Given this list of marker genes PDHX, ACOT11, GLRX, ATP5MGL, GFUS, ERH, AFMID, NT5C, UNG, NDUFB7, ACOT12, GUCY2D (guanylate cyclase 2D, retinal), HAAO, TDG, DNPH1, DHTKD1, PDK2, TPST1, PPCS, ACAT1, BPNT1, PRKACA, CDADC1, TSPO, GPI, PKLR, PMM2 (phosphomannomutase 2), NDUFA2, AADAT (NCBI Gene Id 51166), GCK, GMPPB, ACO1, PRKAG2, PUDP, ACSBG1, CBR4, RRM1, ME1, SDHB, SLC4A1, MYH8 (NCBI Gene Id 4626, myosin heavy chain 8), PFAS, AK4, GARS1, ACSL3 (acyl-CoA synthetase long chain family member 3), KYNU, MYH4, NDUFB2, TMSB4X, HDAC4, TTR, CLPX, NDUFB6, GOT2, SARM1, ENO3, GUCA1A, GDA, PIPOX, INS (NCBI Gene Id 3630), KAT2B (NCBI Gene Id 8850), ADCY9, RORA, SULT2B1, TAFAZZIN, ARL2, PPT2, UGGT1, PGM3, DGUOK, MMUT (NCBI Gene Id 4594), EP300, NUDT10, FLCN, TALDO1, NT5M (5',3'-nucleotidase, mitochondrial), GMPS, NDUFB11, RRM2B, BAAT, MDH1B, ATP5MC2, ACSM2A, PDE8A, PDE1A, ADA, RNASEH2B, GNPNAT1, PAPSS1, NME5, PRPS1L1, ENPP4, NDUFS5, MYH3, HACD1, APOBEC3G, AMDHD2, AICDA, GFPT2 (glutamine-fructose-6-phosphate transaminase 2), MDH2, RD3, MPP1, NDUFA3, TK1, STOML2, ACSM3, DCTD, NTHL1, BCKDK, TK2, GPAT4, PGK1, MAPDA, ATP5MC1, ASPDH, NDUFA5, NUDT13, PTH, PDE7B, HPRT1, ATP5F1C, REXO2, GIT1, FLAD1, ADSL (adenylosuccinate lyase), AMPD2 (adenosine monophosphate deaminase 2), ACOT8, ACACB, PPT1, ACTN3, GNAI3, ATP6V1A, MT-ND1, NUDT1, TGFB1, TJP2, DHFR2, PGM1, ACSBG2, MTHFD1, SLC25A13, BAD, NNT, NUDT15, NME3, NDUFB10, ABCD1, JMJD8, DNAJC30, AK5, ACSM5, EXTL2, PDE7A, SLC2A6, PGD, ATP5MJ, SULT1C4, ACSL6, NUDT14, PPP2CA, ADSS2, OXSM, GFPT1, PRPSAP2 (phosphoribosyl pyrophosphate synthetase associated protein 2), PDE4B (NCBI Gene Id 5142), MT-ATP8, HMGCS1, ATP5MC3, ZBTB7A, SLC52A3 (NCBI Gene Id 113278), ADCY3, PDE4D, PRKAG3, TREX1, IER3, SUCLG2, TPK1, H6PD, TP53I3, SMUG1, DPYSL3, DHODH, PAICS, NUDT16, ATP5PF, UQCC3 (NCBI Gene Id 790955), NUDT9, NT5C1A, SULT1C3, MYH7, IMPDH2, EIF6, PFKFB3, NT5C3B, SHMT1, MGAT1, SRC, P2RX7, MPC2, RPTOR, G6PD, AK1, NDUFB5, TIGAR, ALDH6A1, NMRK2, CMPK2 (NCBI Gene Id 129607), AK3, NUDT4, PFKP, MT-ND6, MLST8, TREM2, DLG1, PAPSS2, LACC1, MACROH2A1, MT-ATP6, DCK, FOXK2, AMPD3, NDUFA13, NDUFA6, IL4, NADK2, BLOC1S6, SLC4A7, SLC27A2, MVD, SDHC, NANP, FCSK, ASMTL, ADCY2, URAD, RRM2, NT5C1B (NCBI Gene Id 93034), NDUFC1, PDE5A, ACMSD, OPA1, HTR2A, BPGM, PPCDC, MAP2K1, MTHFD2L, UCP2, ELOVL7, SNCA, ELOVL5, ATP1B1, ADK, ELOVL4, NDUFS4, ATP6V0C, ACSL1, MVK, UAP1, ADCY7, PFKL, NADSYN1, GAPDH, NUDT8, HSPA8, ACACA, TDO2, PARK7, NMNAT2, AMPD1, BEND3, MFN1, DDIT4, DUT, IDH1, ZBTB20, NDUFA8, MYH6, HSD17B4, ACOT1 (acyl-CoA thioesterase 1), NAMPT, HKDC1, DLG2, COX11, APP, CMPK1, UCK2, CD38 (CD38 molecule), ATP5F1EP2, EFL1, ALDOA, IGF1, PRPS2, PPARA, SUCLA2, ATIC, ACOT2, ITPA, HSPA1B, MACROD1, ENO1, NUDT5, PDK3, PANK4, GAPDHS, PRKN, LRGUK (NCBI Gene Id 136332), TPI1, NANS, PRXL2C, MDH1, OLA1, OGT, CRMP1, PGAM2, AASS, UPP1, THEM5, QNG1, ATP6V1B2, ACSL4, HK1, UXS1, GNPDA1, NOCT, ENPP1, COASY, ADSS1, FHIT, APOBEC3C, NDUFA9, GUCA1ANB-GUCA1A (NCBI Gene Id 118142757), SLC25A18, KARS1, PGLS, CMAS, ELOVL2, TBPL1, GNPDA2, TGDS, LIPA, VPS9D1, IFNG, SULT1A1, FIS1, PGK2, PDHA2, FBP1, NMRK1, PSEN1, HMGCS2, ATP5MK, NT5C3A, SUCLG1, GMDS, GNE, NDUFA11, ATP1A2, DCTPP1, GPAM, AK8, MLXIPL, NDUFV3, SELENON, ELOVL1, ATP7A, NADK, NPPC, AK6, MAPK1 (mitogen-activated protein kinase 1, NCBI Gene Id 5594), UPRT, ADCY10, PDK4, NME7, FAR2, UGDH, SHPK, PARG, ALDH1L2, NDUFB1, GLYAT, GUCY2C, HIF1A, DCAKD, UPB1, HACD2, ARNT, STAT3, GUCY1A2, UGP2 (UDP-glucose pyrophosphorylase 2), PMM1, NDUFS3, LETMD1, NDUFV1, NOX1, NDUFA10, MTAP, HK2, ELOVL3 (NCBI Gene Id 83401), NCOR1, NDUFB9, NUDT2, GALT, DPYS, XDH, DTYMK, ATP5F1D, TP53, PGAM4, DGAT2, ACLY, IDH2, ENTPD1, MT-ND5, VCP (NCBI Gene Id 94731), VNN1, CTPS1, ATP5MF, ENTPD4, MT-ND4L, GUCY1B1, TYMP, MT-ND4, ATP5F1B, ACSF2, DPYD, GCDH, UCHL1, UCK1, CMAHP, TYMS, NUDT3, NUDT19, DPM1, ACOT7, TPST2, PFKFB2, NME4, ME2, PDK1, MT-ND2, GUCY2F, GPD2, ATP5PO, NEIL1, GMPR2, LDHB, RPIA, NDUFS6, ACSL5, NDUFC2, NDUFS1, FMO2, MIR675, SULT2A1, CSGALNACT1, PRTFDC1, NPPA, INSR, UGGT2, CROT, TKT (transketolase), PDE4C (phosphodiesterase 4C), NME2, ACOT6, FAR1, NPR1, ENTPD8, CARD11, DERA, OARD1, ENSG00000293349, ADCY4, NPR2, PRPSAP1, NUPR1, DNM1L, NDUFB8, MCCC2, NDUFB3, SDHA, NAXD, PFKM (NCBI Gene Id 5215), NDUFA12, MCEE, SLC25A25, FITM2, PRPS1, KMO, IMPDH1, DGAT1, RAN, CTPS2, HMGCR, SLC25A22, CASK, FIGNL1, ADA2, FUOM, PDHA1, NDUFV2, NAPRT, ALDOC, ENO2, CTNS, ICMT, PDE4A, MLYCD, MTCH2, PGM2, PRKAA1, NAXE, DMAC2L, ADCY6, NDUFS2, PNP, OGDH, ACP3, PGAM1, IDO2 (NCBI Gene Id 169355), PTHLH, HSPA1A, ATP5IF1, DIP2A, NUDT11, TECR, LDHA, DPYSL2, SLC35A3, SLC25A11, GALK1, ATP5ME, ATP5MG, ENPP3, COL6A1, ACSM6, SLC35C1, NMNAT3, NT5C2, OGG1, GMPR, PANK2, GPD1, NDUFA7, PANK3, NUDT7, NME1, CAD, QPRT, GNMT, CACNB4, ALDH1L1 (aldehyde dehydrogenase 1 family member L1), ACOT9, NEIL2, ENTPD2, ACSF3, ATP5F1E, NMNAT1, PRKAG1, SULT1B1, PKM, OGDHL, ATP5PD, PARP1, NPPB, RPE, SULT1A3, FPGT, PINK1, GUCY1A1, ACSM1, RAB23, EPHA2, GUK1, MAGI3, ADPGK, ADCY8, ATPSCKMT, ABHD14B, NME9 (NME/NM23 family member 9), UCKL1, MACROD2, UAP1L1, FAM3A, LRRK2, ABCC6, NDUFS7, NDUFAB1, NDUFS8, AK7, SULT1E1, CDA, SMPDL3A, PC, ADCY5, NUDT12, MPI, ATP5F1A, NME6, DCXR, DLST (NCBI Gene Id 1743), ANTKMT, SULT1A2, ABCC9, NAGK, ATP6V1B1, UPP2, KDM1A, IDO1, FUT8, CNP, HTD2, PDHB, RPEL1, ATP5PB, SPHK2, MT-ND3, GIMAP7, TRIM63, CPS1, DPYSL5 (NCBI Gene Id 56896), AK2, FKRP, NDUFB4, ADCY1, NUDT4B, RBKS, CBFA2T3, ELOVL6, FOXK1, NDUFA1, ENTPD3, PANK1, NT5E, LDHC, PMVK, GTPBP1, ACSM2B, PID1, SLC25A12 (solute carrier family 25 member 12), MBD4 (NCBI Gene Id 8930), RFK, HK3, PDE10A (phosphodiesterase 10A), BCL2L13, ALDOB, ACSM4, DPYSL4, DLD, SLC4A4, HINT1, FASN, MFSD8, GSK3A (NCBI Gene Id 2931), AK9, ACOT4, PRKAA2, GPD1L, B4GALNT2, GOT1 (glutamic-oxaloacetic transaminase 1), SULT1A4, UMPS, NUDT18, ACSS1, HSD17B12, SIRT6, NUDT17, SAMHD1, SDHD (succinate dehydrogenase complex subunit D), ENTPD7, GMPPA, PTGDR, SLC35A1, MTOR, ENO4, ACSS2, PDE2A, GART, APRT, RHOQ, PPAT, DLAT, PFKFB1, PDE9A, ENTPD5, NME2P1, PDE8B, here is a description of the gene set: The cellular chemical reactions and pathways involving a nucleobase-containing small molecule: a nucleobase, a nucleoside, or a nucleotide. species: Homo sapiens Human Gene Set: GOBP_NUCLEOBASE_CONTAINING_SMALL_MOLECULE_METABOLIC_PROCESS